The following is a description of a gene set: studied in species Homo sapiens The process in which an immature T cell commits to CD4-positive T cell lineage or the CD8-positive lineage of alpha-beta T cells. Human Gene Set: GOBP_CD4_POSITIVE_OR_CD8_POSITIVE_ALPHA_BETA_T_CELL_LINEAGE_COMMITMENT, and this is the list of marker genes: IL6, IL23R, IL12RB1, CD69, IL6R, MTOR, IRF4, BRAF, JAK3, LOXL3 (lysyl oxidase like 3), IL23A, SPN, OPA1, STAT5A, IL6ST, JAK1, LGALS1, ZFPM1, TOX, SLAMF6, BCL2, TNFSF18, STAT3, CTSL, STAT6, SHH, TBX21, BRD4, CYLD, SOCS3, EP300, BRD2, BATF, LY9, FOXP3, IL12B